Given this list of marker genes DYNC1LI2, HOXA9, NRBP2, ANKRD46, RBP7, NT5DC1, CDNF, KLHL29 (kelch like family member 29), SNHG9, PTK2, LAMA2, ORC6, DSCC1, CD109, TRAM1, SLC7A2, TMC5, LXN, KBTBD11, IST1, QPRT, USO1, CHMP1A, FA2H, FAM8A1, USP33, RIDA, EIF1AD, RPL13, APRT, PTGR1, LRIG1, VPS28, H3C10, PCOLCE2, ST6GALNAC3, LAMA3, RNF175, HOXB-AS3, ZNF32, APOC1, CFDP1, NUDT16L1, RBL2, WAS, UQCC4, UFL1, TMEM106C (NCBI Gene Id 79022), GNG12, CENPS, TIMM23, NUDT3, NBN, TENT4B, GINS2, GPRC5B (NCBI Gene Id 51704), MYEF2, CLUAP1, DDHD2, SLIT2, BRK1, CYB5B, TMEM14C, TRIB1, CFAP99, JPT2, MON1B, IDH2, DNPH1, POLR3K, ACTA2, TRAPPC2L, TMTC4, FAXC, LRP2, PCDH19, MLYCD, ADAM9, ANKRD11, VKORC1, AGA, NQO2, KRTAP2-3, SENP6, RPL30, ERLIN2, RMI2, GLCE, SIAH1, SCRG1, NDUFB10, PPARG, GK3 (glycerol kinase 3), MAP7D2, CHCHD4, INTS10, PLCG2, LGI3, FRRS1L, HOXA5, UQCRB, CHKB-DT, EIF4EBP1, DEPTOR, ETFB, HAGH, SPATA8, GSPT1, CENPN (centromere protein N), LY6G6D, ZNF600, SPG7, FDPS, CHD9, ZNF468, HSBP1, PCBD1, NAALADL1, SCRIB (scribble planar cell polarity protein), CIAPIN1, AARS1, JAGN1, PIGV (NCBI Gene Id 55650), MCUR1, ITFG1, HDDC2, INTS9, ANKRD13C, ENPP2, CA2, NAE1, AVEN, PINX1, SERPINB6, FAM241B, CD84, NINJ2-AS1, HSDL1, RFC5, GGH, AGAP3, PCDH7, LSM1, RDH10, RNF168, ZMYND11, ZNF83, LONRF1, DUSP22, LEPROTL1, ASB13, PKP2, ECHDC2, TCF25, NDUFAB1, MRPL15, ASPH, TSPO, TMEM18, TRMT11, NIPSNAP1, ZNF610, EBAG9, ZNF700, MRTFB, ZFP90, MBTPS1, B9D1, RNF128, MMAB, USP7, EIF3H, FTO, SH3TC2, DPH6, PON2, RPL32, SERPINB1, NUDT21, H2AJ, TMEM161B-DT, ZNF599, ATMIN, CCDC167, SULT1A1, ZBED5-AS1, ZNF91, CTH, OGFOD1, FABP5, RPL8, TANGO6, PTPMT1, CYBA, C2orf74, MPHOSPH6 (M-phase phosphoprotein 6), REXO5, OXCT1 (NCBI Gene Id 7898), here is a description of the gene set: Active immunotherapy is a promising strategy for anti-angiogenic cancer therapy. Recently, we have reported that a vaccine using human umbilical vein endothelial cells (HUVECs) induced specific anti-endothelial immune responses in the most of immunized patients, and resulted in tumor regression in some patients with recurrent malignant brain tumors, whereas not in colorectal cancer patients. In this study, we hypothesized that non-hypoxic perivascular tumor associated macrophages (TAMs) in colorectal cancer, but not in glioblastoma, might negatively alter the therapeutic efficacy of anti-angiogenic active immunotherapy. To test this hypothesis, we examined global gene expression profiles of non-hypoxic macrophages stimulated in vitro by soluble factors released from tumor cells of human glioblastoma U-87MG (‘brain TAMs’) or colorectal adenocarcinoma HT-29 (‘colon TAMs’). Human Gene Set: GSE18804_SPLEEN_MACROPHAGE_VS_TUMORAL_MACROPHAGE_DN studied in species Homo sapiens Genes down-regulated in macrophages: control versus tumor associated.